The following is a description of a gene set: from publication Cao J, O'Day DR, Pliner HA, Kingsley PD, Deng M, Daza RM, Zager MA, Aldinger KA, Blecher-Gonen R, Zhang F, Spielmann M, Palis J, Doherty D, Steemers FJ, Glass IA, Trapnell C, Shendure J (PMID 33184181) Marker genes curated from the annotated cluster as represented in the Descartes Human Gene Expression During Development database. Human Gene Set: DESCARTES_MAIN_FETAL_VASCULAR_ENDOTHELIAL_CELLS studied in species Homo sapiens The gene expression program underlying the specification of human cell types is of fundamental interest. The study authors generated human cell atlases of gene expression and chromatin accessibility in fetal tissues. For gene expression, the study authors applied three-level combinatorial indexing to >110 samples representing 15 organs, ultimately profiling ~4 million single cells. The study authors leveraged the literature and other atlases to identify and annotate hundreds of cell types and subtypes, both within and across tissues. Our analyses focused on organ-specific specializations of broadly distributed cell types (such as blood, endothelial, and epithelial), sites of fetal erythropoiesis (which notably included the adrenal gland), and integration with mouse developmental atlases (such as conserved specification of blood cells). These data represent a rich resource for the exploration of in vivo human gene expression in diverse tissues and cell types., and this is the list of marker genes: FCGR2B, ENSG00000233251, FCN2, SOX7, NODAL, OIT3, ROBO4, RFLNB, SNRK, TM4SF18, EGLN1, CRHBP, APLNR, ESM1, C1QTNF9, RFPL1, ADGRL4, NOTCH4, FOXF2, CD300LG, RAPGEF5 (Rap guanine nucleotide exchange factor 5), ENSG00000248636, FAM167B, ABCB1, SELE, APLN, LINC02172, SHANK3, DLL4, LDB2, CAV1, PRND, DGKE (NCBI Gene Id 8526), ARHGEF15, SLC9C1, LXN, SLC39A10, LINC02043 (long intergenic non-protein coding RNA 2043), TCF15 (NCBI Gene Id 6939), HLX, PTPRB, MTMR9LP, EEF1A1P31 (eukaryotic translation elongation factor 1 alpha 1 pseudogene 31), JCAD, FCN3, CIMAP1D (CIMAP1 family member D, NCBI Gene Id 284451), FAM124B, SLCO1A2, CYYR1, TCIM, SRARP, RASIP1